The following is a description of a gene set: Human Gene Set: HP_PATENT_FORAMEN_OVALE studied in species Homo sapiens Failure of the foramen ovale to seal postnatally, leaving a potential conduit between the left and right cardiac atria. Patent foramen ovale, and this is the list of marker genes: SDHD, TSFM, ESAM, MID1, FLNA, FRA10AC1, GNPTAB, HACD1, IPO8, TMEM94, MED12, ACADVL, CREBBP, CEP295, CHMP1A, ALG12, UBR7, CCNQ, BICRA, GNB5, DPF2, DVL3, MAP3K7, STAMBP, COL11A1, CLXN, FIG4, PRR12, AMMECR1, DSE, CDC42BPB, WLS, ANAPC7 (NCBI Gene Id 51434), ATP6V1E1, NKX2-5, ZIC3, NOTCH1, PACS1, NDE1, STAG2, IFT56, FANCI, KDM1A, SMAD6, AGO2, STAT1, CACNA1D, MED13L, TBX5, PLD1, PPP1CB, TKT (NCBI Gene Id 7086), PKDCC, WDR37, LZTR1, AFF4, POLR1A, MTX2, SMC3 (NCBI Gene Id 9126), EP300, TALDO1, RAC1, RPL3L, VPS33A, RAI1, B3GAT3, LMNB1, SMG8, RNU4ATAC, ATN1, SH3PXD2B, FBXL4, KMT2D (lysine methyltransferase 2D), MRPL3, RIPK4, UBE2A, LONP1, OCLN, DAW1, KRAS, TGFBR2, TWIST1, NAA10, RERE, FOXF1, NCAPG2, TMEM147, PRIM1, PPP2R5D, PIGN, WDR35 (NCBI Gene Id 57539), CACNA1C, CDK8, YY1, HSPA9, ZNF699, SNRPN, MAX, UFC1, TRIP4, THSD1, RSPRY1, NF1, VPS33B, ROBO1, GATA6, FOCAD, NIPBL, POGZ, TGFB3 (NCBI Gene Id 7043), KATNB1, ASCC1, TBX20, SCUBE3, STK4, FLCN, TRRAP, CIROP, KDM6A, DDX6, CHST3, NONO, NRAS, IGF1R, MED11, DNA2, SUCLG1, TASP1, PPP1R13L, RELN, NKX2-1, CSGALNACT1, SETD1A, EHMT1, FBXW11, LTBP4, PHGDH